The following is a description of a gene set: Mouse Gene Set: MIR_1964_5P Genes predicted to be targets of miRBase v22 microRNA mmu_miR_1964_5p in miRDB v6.0 with MirTarget v4 prediction scores > 80 (high confidence targets). studied in species Mus musculus from publication Chen Y, Wang X (PMID 31504780), and this is the list of marker genes: Mup5, Pde10a, Prtg, Smg7, Tob2, Cldn5, Zhx2, Ppp1r12a, Inpp5j, P2rx3, Serf2, Zkscan8, Fbxo11, Map2k6, Gmnc, Derl3, Garem2, Pfn2, Limd2, Cfl2, Csnk1g1, Senp1, Glud1, Zfp142, Dtd1, Rap1gap2, H2bw2, Micos10, Rnft1, A4gnt, Slc17a9, Aldh7a1, Efr3b, Xpr1, Ctla4, Kmt5b, Ceacam20, Tmem104, Mfsd2b, Slc22a23, Ube2d1, Sstr5, Foxn4, Map1s, Pacs1, Tmed8, Rela, Pttg1ip, Ttc21b, Flt4, Rps6ka2, 6430571L13Rik, Atrn, Gm6760, Opcml, Slc20a2, Edc3, Fbxl20 (NCBI Gene Id 97750), Stk11ip, Ube2ql1, Klf9, Tmem164, Csdc2, Pou2f2, Stx1a, Dffa, Esm1, Kdm3b, Mup3, Purg, Syna, Plxna4, St6galnac6, Zfp174, Mup4, Klhl18, Rhoa, Macrod2, Srf, Gata4 (GATA binding protein 4), Got2, Pten, Bloc1s5, Ybx1, Icos, Sgo1, Msantd1, Krbox5, Wdr12, Kif21b, Rhbdf2, Flot2, Pnp, Vat1, Slc1a1, Mob1b, Cs, Eps8l1, Lamc1, Zfp704, Rsad1 (NCBI Gene Id 237926), Rbbp5, Gm4952 (predicted gene 4952), Irs1, Casq2, Pakap, Mapk8ip3, Npy6r, Pitpnc1